The following is a description of a gene set: from publication Bedogni F, Hevner RF (PMID 34321999) species: Mus musculus Genes selectively expressed by intermediate progenitor cells (apical subtype) in embryonic day 14.5 mouse cortex Mouse Gene Set: HEVNER_CORTEX_APICAL_INTERMEDIATE_PROGENITOR_CELLS, and this is the list of marker genes: Neurog2, Mir17hg (NCBI Gene Id 75957), Srsf2 (NCBI Gene Id 28128), Abcf1, Chd7, Inppl1, Hes6, Boc, Rhbdl3, Rai14, Dll1, Snrnp40